Given this list of marker genes DMBX1, TGFBR2, ZNF430, TSN, EIF4G1, TRIM40, PTAFR, NDUFAF7, PNMA8A, PRRG4, MRPL57, XIAP, ARHGEF39, NPHP3, ERBB3 (erb-b2 receptor tyrosine kinase 3), RAB3IP, TGFBR1, ZNF486, VWA8, PPP1R12B, RAD21, CDAN1, MMGT1, CCDC170, IL12RB2 (interleukin 12 receptor subunit beta 2), WDR36, IVD, UBXN2A, POU3F2, SVEP1, ZNF135, GINS1, CORO2A, PDE12, C17orf75, SRSF10, C9orf85, RSPO3, ZNF34, ENOSF1, ZNF699, TRPM7, DCAF11, EPS15, TARS2, PPM1K, METTL2B, RBM27, GPR82, CPM, ZC3H7A, LAMP1, MARVELD3, PIGA, IRF1, RINL, CAVIN1, OPA3, BMP7, ARL4D, KLF12, SULT4A1, METTL2A, TFAP2C, SFTPB, ZNF276, ZNF320, IKZF3, GEMIN8, GDPD1, MBD2 (methyl-CpG binding domain protein 2), RAB42, VPS4B (NCBI Gene Id 9525), TGFA, HECW1, GJC1, CGGBP1, TPM3, ANGPT1, PALM2AKAP2, CMBL (carboxymethylenebutenolidase homolog, NCBI Gene Id 134147), HILPDA, TMEM248, TAF8, ZMYM4, LSM14A, SNX22, C15orf40, INIP, MND1, MINDY2, EXOC3L2, UBL3, SPTLC1, ZNF527, CCN2, GPSM2, TRIM33, ABCD3, XPNPEP3, ABHD11, C9orf78, CAMK1D, USP3, ESCO2, DNAJB5, BCL11A, TMEM213 (NCBI Gene Id 155006), PBLD (NCBI Gene Id 64081), MFSD11, RIC8A, SCN2A, TMC5, RPL7L1, EIF3I, PELATON (plaque enriched lncRNA in atherosclerotic and inflammatory bowel macrophage regulation), CTSB, CDA, SCN3A, DZANK1, IMPA1, VHL, ACTG1, FLT1, AVIL, VLDLR, UTRN, PDAP1, NDST3, LGI2, FAM83E, PODNL1, GK5, FAM227A, ARHGEF38, CTSS, DENND2A, HSF2, ZNF519, MTF2, WDR17 (NCBI Gene Id 267003), GSK3B, CDHR3, DCLRE1C, CCSER2, DNPEP, CAST, CXorf38, GOPC, KCNN3, DNAL1, RORA, DUSP16, SLC31A1, CCDC142, DCAF10, FGFR2, GLUL, CACNG8, RAB2B, MOGAT3, MRRF, SPRY3, TMC7, IAPP, EIF4G2, ZFP14, WDR73, FHAD1, DNAAF6, QNG1, GPR65, ZNF557, PNPLA1, LETM2, RAB11FIP1, ITIH2, KPNA6, TRIM72, RAB28, CEP126, CIAO1, AK1, DCX, TSHZ1, DTWD1, DCAF16, ZNF426, CRIM1, C1orf43, HCN1, KREMEN1, SLC50A1, FBXO27, MIGA1, DHTKD1, SPATS2, GCLM, LINC02908, EFHB, ELOC, ABHD18, GPATCH2L, PDE4C, POLH, HIVEP3, VSIG1, SAMD8, TMOD2, SDC3, CD84, ADAT1, WAC, VRTN, GTF3C4, MTCL1, USP32, DNAJC22, TNFSF14, JARID2, TSHZ2, SMYD4, TNFRSF10A, HMGN3, METTL6 (methyltransferase 6, tRNA N3-cytidine), ZNF865, NR2C1, KPNA1, CDC37L1, GATAD1, LIMD1, SMIM14, FKBP14, ZFP82, CHST6, CYP20A1, NGF, SON, PRR11, RBM47, VKORC1L1, SEC61G, PPP1R3B, ZFAND5, TTC23L, PLPBP, ZNF563, ZNF841, ZIM3, ZNF688, DDX51, FGD4, MRM2, WDFY3 (WD repeat and FYVE domain containing 3), TRMT9B (tRNA methyltransferase 9B (putative)), ARCN1, SLC16A14, PUM2, PNPT1 (polyribonucleotide nucleotidyltransferase 1, NCBI Gene Id 87178), SNAP29, ZNF555, FADS1, SUN3, GLB1L, SYNJ2BP, CABP4, GINS4, ZNF621, MTRF1, LIMS1, ZBTB8A, WDR31 (WD repeat domain 31), RMND1, E2F5, here is a description of the gene set: from publication Chen Y, Wang X (PMID 31504780) species: Homo sapiens Genes predicted to be targets of miRBase v22 microRNA hsa-miR-7151-3p in miRDB v6.0 with MirTarget v4 prediction scores > 80 (high confidence targets). Human Gene Set: MIR7151_3P